The following is a description of a gene set: Human Gene Set: MIR10396A_5P Genes predicted to be targets of miRBase v22 microRNA hsa-miR-10396a-5p in miRDB v6.0 with MirTarget v4 prediction scores > 80 (high confidence targets). species: Homo sapiens from publication Chen Y, Wang X (PMID 31504780), and this is the list of marker genes: NFIX (nuclear factor I X), L3MBTL2, IQSEC2, ROR2, RGMA, SURF4, AP5Z1, PELI3, HS6ST1